The following is a description of a gene set: After Pol II pauses by back tracking 2 -4 nuleotides on the HIV-1 template, elongation of the HIV-1 transcript resumes. Reactome Pathway: Pausing and recovery of HIV elongation species: Homo sapiens part of: Transcription of the HIV genome, and this is the list of marker genes: ELOB, GTF2F2, CCNK, CDK9, SUPT16H, GTF2F1, POLR2L, POLR2F, POLR2I, POLR2A, NELFCD, ELOC, POLR2H, CCNT2, CCNT1, POLR2G, POLR2E, SSRP1, POLR2D, CTDP1, SUPT4H1, SUPT5H, NELFE (negative elongation factor complex member E), POLR2B, ELL, ELOA, NELFB, NELFA, TCEA1, POLR2K, ELOA2 (NCBI Gene Id 51224), POLR2J, POLR2C